The following is a description of a gene set: studied in species Mus musculus Binding to a microtubule, a filament composed of tubulin monomers. Mouse Gene Set: GOMF_MICROTUBULE_BINDING, and this is the list of marker genes: Kif26a, Ogg1, Kif6, Spef1l, Kif27 (kinesin family member 27, NCBI Gene Id 75050), Clasp1 (NCBI Gene Id 76707), Rmdn2 (regulator of microtubule dynamics 2), Ccsap, Togaram2, Ska1, Svbp, Nde1, Kif11 (kinesin family member 11), Kif21b, Fsd1, Mapre2, Cryab, Nusap1, Fbxw11, Kif19a, Mtcl1, Ccdc66, Kif17, Spire2 (NCBI Gene Id 234857), Krit1, Eml6, Tmod3, Apc, Cetn1, Drg1, Kif13a, Map1s, Vapb, Kif15, Spc24, Klc3, Tubgcp5, Nme8, Map10, Camsap2, Tubgcp4, Knl1, Haus8, Traf3ip1, Kif19b, Cenpe, Spata4, Reep2, Kif12, Kif20b, Mtus2, Clip1, Trim54, Gli1, Kif2b, Vapa, Cep44, Gas2l1, Eml3, Polb, Irag2, Cript, Spag8, Map7d3, Fes, Cep135, Katnal1, Cep290, Reep3, Katnal2, Akap1, Sbds (NCBI Gene Id 66711), Gtse1, Gapdhrt, Knstrn, Dnm2 (dynamin 2), Gjb6, Dnai7, Ssna1, Nav3, Numa1, Kif4, Cetn2, Capn6, Kif1a, Golga2 (golgin A2), Prc1, Dst, Tiam1, Ska3 (spindle and kinetochore associated complex subunit 3), Pafah1b1, Enkd1, Chp1, Rp1, Hook1, Map1lc3a (microtubule-associated protein 1 light chain 3 alpha), Ppp5c, Kif3c, Kif24, Haus6, Strbp, Mark4, Gabarap, Fmn1, Tppp, Kifc3, Haus4, Luzp1, Cep57, Ccdc88a, Gapdh, Katnbl1, Kif18b, Ccdc61, Kif26b, Kif18a, Rcc2, Mast1, Dlgap5, Kif9, Fmn2, Spast, Mx2, Clip4, Nuf2, Cep295, Ezr, Reep1, Prnp, Camsap1, Kif3b, Ccdc69, Map6d1, Zfp207, Eml4, Ndrg1, Spag6l, Spag5, Dysf, Snca, Bcl2l11 (NCBI Gene Id 76339), Map1b, Kifc1, Mlph, Mapt, Kif14, Kif7, Tubgcp2, Kif3a, Maco1, Ccdc88b, Wdr90, Jakmip3, Dnm1l, Map4, Dcx, Diaph3, Cep350, Reep4, Vps41, Saxo2, Nin, Katnb1, Trim46, Jmy, Kif2c, Hdgfl3, Clasp2, Spire1, Cgn, Katna1, Clip3, Dnm1, Jakmip1, Eml1, Arhgef2, Nf1, Kif5a, Clip2, Plk1, Kif5b, Kif16b (NCBI Gene Id 99070), Cetn3, Rmdn1, Hook2 (hook microtubule tethering protein 2), Rab11a, Ccdc170, Macf1, Arl3, Kif2a, Gas8, Trpv4, Ccdc88c, Kifc5b, Fmr1, Mast2, Fhdc1, Sybu, Abraxas2, Tubgcp3, Map9, Eml2, Camsap3, Kifc2, Vash2, Tbcb, Fgf13, Ckap5, Pex14, Cnn3, Ccdc187, Whamm, Cdk5rap2, Map1a, Rgs14, Mid2, Abraxas1, Eml5, Terf1, Hook3, Saxo1, Dnm3, Ndc80, Kif23, Kif1c, Psrc1, Tubgcp6, Cfap157, Haus7, Racgap1, Map1lc3b, Kif22, Spag6, Gapdhrt2, Tpgs1, Mtus1, Ftcd, Kif21a, Sgip1, Stim1, Dclk2, Mdm1, Mapre3, Fam83d, Ska2, Togaram1, Stard9, Fam161a, Kif5c, Mapre1, Cfap144, Map4k4, Kif13b, Kif28, Ccdc181, Gas2, Neil2, Gas2l3, Dync1i1, Apc2, Mid1, Ndel1, Gas2l2, Rps3, Fnta, Spaca9, Dctn1, Rmdn3, Spef1, Cep57l1, Kif20a, Map6, Appbp2, Hdac6, Opa1, Map2, Ccser2, Kif1b, Map7d2, Birc5